The following is a description of a gene set: studied in species Mus musculus Any process that modulates the rate, frequency, or extent of dendritic spine morphogenesis, the process in which the anatomical structures of a dendritic spine are generated and organized. A dendritic spine is a protrusion from a dendrite and a specialized subcellular compartment involved in synaptic transmission. Mouse Gene Set: GOBP_REGULATION_OF_DENDRITIC_SPINE_MORPHOGENESIS, and this is the list of marker genes: Tanc2, Dtnbp1, Nlgn1, Actr2, Reln, Bhlhb9, Lrrk2, Arc, Kalrn, Afdn, Srcin1, Dhx36, Dbnl, Tiam1, Cdk5r1, Dnm1l, Mfn1, Slc30a1, Arhgap44, Cux2, Xlr3b, Marcks, Nlgn3, Zdhhc15, Epha4, Baiap2, Abi3, Cfl1, Abi2, Ppfia2 (NCBI Gene Id 327814), Caprin2 (caprin family member 2, NCBI Gene Id 232560), Il1rapl1, Camk2b, Dbn1 (drebrin 1), Sipa1l1, Arhgap33, Dnm3, Ube3a, Ppp1r9a (NCBI Gene Id 72734), Efna1, Pten, Ptprd, Pdlim5, Adam10, Shank3, Itpka, Cask, Mfn2, Lrp8, Actr3, Ngef, Stau2, Pafah1b1, Eef2k, Caprin1 (cell cycle associated protein 1), Pak3, Cdk5, Opa1, Ephb2, Abi3bp, Kif1a, Lzts3